Given this list of marker genes Rnf41, Mtmr9, Pptc7, Rragd, Lepr, Clec16a, Eif4g2 (NCBI Gene Id 77989), Washc1 (WASH complex subunit 1), Lzts1, Mtm1, Slc7a5, Phf23, Mapk8, Bmf, Fez2, Lep, Tsc1, Fez1, Wnk1, Npc1, Rptor, Ptk2, Herc1, Il3, Dap, Tspo, Nupr1, Rnf5, Nampt, Akt1, Lrrk2, Stat3, Tsc2, Stk38l, Wdr6, Scfd1, Htra2, Foxk2, Hmox1, Usp36, Klhl22, Ctsa, Adra1a, Qsox1, Tigar, Pink1, Dapl1, Il10, Gata4, Sirt2, Hdac6, Tnfaip3, Eif4g1, Tmem39a, Ikbkb, Ubqln4, Chuk, Cptp, Poldip2, Fn1, Rraga, Trem2, Vps13c (vacuolar protein sorting 13C), Sec22b, Trim27, Trp53, Foxk1, Mcl1 (myeloid cell leukemia sequence 1), Il10ra, Rubcn (NCBI Gene Id 67910), Ep300, Golga2, Nrbp2, Bcl2, Fbxl4, Zkscan3, Rasip1, Smcr8, Mlst8, Itgb1, Becn1, Rragc, Tbc1d14, Ehmt2, Kdm4a, Lypla1 (NCBI Gene Id 18777), Rragb, Snca, Erfe, Itga5, Usp30, Ptpn22, Mtor (mechanistic target of rapamycin kinase), here is a description of the gene set: species: Mus musculus Mouse Gene Set: GOBP_NEGATIVE_REGULATION_OF_AUTOPHAGY Any process that stops, prevents, or reduces the frequency, rate or extent of autophagy. Autophagy is the process in which cells digest parts of their own cytoplasm.